The following is a description of a gene set: Mouse Gene Set: GOBP_PLATELET_DERIVED_GROWTH_FACTOR_RECEPTOR_ALPHA_SIGNALING_PATHWAY The series of molecular signals initiated a ligand binding to an alpha-type platelet-derived growth factor receptor (PDGFalpha) on the surface of a target cell, and ending with the regulation of a downstream cellular process, e.g. transcription. species: Mus musculus, and this is the list of marker genes: Pdgfrb, Phf14, Epha10 (Eph receptor A10), Erbb4, Fgfr4, Insr, Ret, Ephb2, Epha5, Mst1r, Insrr, Ephb3, Erbb2, Epha1, Ltk, Fgfr2, Flt4, Epha3, Kdr, Fgfr3, Cbl, Ntrk3, Flt1, Csf1r, Tek, Ntrk1, Epha2, Epha4, Ift20 (intraflagellar transport 20), Musk, Ddr2, Axl, Ror2, Alk, Flt3, Met, Epha8, Igf1r, Cblb, Pdgfra, Epha6, Tyro3, Fgfr1, Egfr, Ros1 (Ros1 proto-oncogene), Adipoq, Tie1, Pdgfa (NCBI Gene Id 18590), Mertk, Epha7, Ephb1, Kit, Ntrk2, Ephb4, Ddr1